The following is a description of a gene set: species: Mus musculus from publication Chen Y, Wang X (PMID 31504780) Mouse Gene Set: MIR_494_5P Genes predicted to be targets of miRBase v22 microRNA mmu_miR_494_5p in miRDB v6.0 with MirTarget v4 prediction scores > 80 (high confidence targets)., and this is the list of marker genes: Sat1, Lman1, Il1a, Postn, Trpc6, Clec7a, Pdgfc, Pde1a, Lrrc8a, Patl1, Rora, Ptbp2, Rnf24, Il12b (NCBI Gene Id 16160, interleukin 12b), Npas3, Npy1r, Clip4, Ndufab1, Itga6, Tspan11, P3h1, Adcyap1, Tnfsf10, Camk2b, Ptpn13, Dst, Hspd1, Chp1, Plod1, Olfml3, Clca2, Ubtf (upstream binding transcription factor, RNA polymerase I), Pik3r3, Rsf1, Taf5, Nhlh2, Pigz, Fmn2, Rad23b, Lrrc20, Alox8